The following is a description of a gene set: Human Gene Set: chr11q24 species: Homo sapiens, and this is the list of marker genes: HSPA8 (heat shock protein family A (Hsp70) member 8), OR8B12, OR8B2, PATE3, OR10G8, MIR100HG, KIRREL3, OR10G9, RPL34P23, OR8F1P, NFRKB, ETS1-AS1, LINC02551, OR8D1, OR8B4, BARX2, JHY, SORL1, BMPR1AP2, MIR8052, OR8B5P, PRDM10 (PR/SET domain 10), KRT18P59, HEPACAM, HYLS1 (HYLS1 centriolar and ciliogenesis associated), TMEM45B, OR10N1P, CLMP, ARHGAP32, OR8B9P, ROBO4, OR8A1, OR6T1, MIR3167, OR8G2P, KIRREL3-AS2, OR8G7P, RN7SL778P, OR8B10P, DDX18P5, RN7SL351P, UBASH3B, OR10S1, SORL1-AS1, ZBTB44-DT, SPA17, OR8Q1P (olfactory receptor family 8 subfamily Q member 1 pseudogene), PKNOX2-AS1, KIRREL3-AS3, OR8C1P, OR8B8, BAK1P2, OR10D5P, RPUSD4, VSIG2, PRDM10-DT, RNU6-592P, RPL35AP26, RNU4ATAC5P, ENSG00000287666, OR8G5, FEZ1, CRTAM, OR6M3P, ZNF202, ENSG00000255087, OR4D5, ELOBP2, KCNJ5-AS1, RNU6-1156P, OR10D3, PUS3, SCN3B, VSIG10L2, RN7SKP279, SRPRA, LINC02873, ETS1, TMEM218 (transmembrane protein 218), OR8G3P (olfactory receptor family 8 subfamily G member 3 pseudogene), NDUFAF2P2, RNU4-23P, SNORD14D, ENSG00000254607, CCDC15, FOXRED1, OR10G7, RPS27P20, RNU4ATAC10P, OR6X1, BLID, SNORD14C, MIRLET7A2, DNAJB6P1, HEPN1, SLC5A4P1, OR8A3P, ENSG00000245008, APLP2, TP53AIP1, GRAMD1B, CHEK1, NRGN, KCNJ1, ACRV1, MIR6090, OR8A2P, RPL31P47 (NCBI Gene Id 100271481), LINC02712, RNU4-86P, STT3A, PATE2, NAP1L1P1, ENSG00000307024, OR10D4P, OR8G1, ESAM, SIAE, OR10G5P, PKNOX2-DT, DDX25, RPS26P43, OR10G6, MSANTD2-AS1, TBRG1, BSX, OR8B3, CCDC15-DT, SF3A3P2, DCPS, ENSG00000239079, OR10D1P, PANX3, LINC01395 (long intergenic non-protein coding RNA 1395), EI24, KIRREL3-AS1, ENSG00000200496, OR8D2, RNA5SP352, LINC02725, LINC02098, OR8B1P, OR8B7P, ENSG00000255537, OR10G4, OR6M2P, ST14, RN7SKP121, MIR4493, TMEM225, OR8B6P, MSANTD2, KCNJ5, ENSG00000260209, PPP1R10P1, PATE1, ZNF123P, ADAMTS8, ENSG00000255317, RNU1-21P, MIR100, GSEC, NRGN-AS1, SENCR, PATE4, ENSG00000296974, ENSG00000301321, SNORD14E, RNU2-35P, LINC02727, ZBTB44, RNU6-876P, ATP5PBP5, CDON, OR8X1P, TIRAP, RNU6-321P, FAM118B, SAE1P1, OR6M1, ESAM-AS1, RNU6-874P, RNU6-256P, ST3GAL4, VWA5A, GLULP3, ADAMTS15, PHB1P17, TIRAP-AS1, SLC37A2, PKNOX2, FLI1, OR8D4, ROBO3, MIR125B1, RPL34P21